Given this list of marker genes NDUFS6, ATP6V0B, MAFG, NFKB1, CEBPD, UQCRB, RBPJ, STAT1, KAT5, CEBPB, NDUFV1, ATP5PO, NDUFB5, BORCS8-MEF2B, ATP5F1D, NDUFS4, YBX1, NDUFB3, POLR2F, NFE2L1, REL, NMI, ATP6V0C, NDUFV2, ATP5F1E, NDUFC1, ATP6AP1, IRF1, POLR2I, ATP6V1B2, CBFB, ATP5ME, FOXO4, UQCRC2, PPA1, UQCRC1, NDUFS3, ATP6V1F, ATP6V1G1, NDUFS5, TXNL1, POLR2G, TSC22D1, ATP5F1B, NFATC4, POLR2E, BTF3, SNAPC1, ELF4, ATP5MF, NR3C1, NDUFS8, here is a description of the gene set: Phosphate metabolism. Human Gene Set: MODULE_273 species: Homo sapiens